Given this list of marker genes DPY19L1, USP28, SAP30, UTRN, MYBL1 (NCBI Gene Id 649850), MAP3K8, EOGT, TP53INP1, SLC27A3, TPM4, RHBDF2, KLRD1, PAM, MIAT, CYTOR, GAB3, ABCA2, CMC1, ELP3, RAP1GAP2, SESN2, SYTL3 (NCBI Gene Id 94120), TLR3, MIR155HG, TOB2, TTYH2, EOMES (eomesodermin), TOX, ANXA2, CAPN2, STARD3NL, PTP4A2, GYG1, ATXN1 (ataxin 1), SYT11, ADGRG1, RHOU, PTGDR, SH3BP5, MICAL2, CD58, KLRG1, LPCAT1, PDGFD, NKG7, CPEB2, ECPAS, JAZF1, WIPI1, GLCCI1, APMAP, GALM, SFXN3, HACD4, YWHAQ (tyrosine 3-monooxygenase/tryptophan 5-monooxygenase activation protein theta), BLVRA, ZEB2, SMAD3, PIF1, GALNT3, MDFIC, GZMA, TBK1, BHLHE40, MAN1A1, NUDT19, GFI1, PRR5L, LAG3, CLEC2B, SPATS2L (spermatogenesis associated serine rich 2 like), NIBAN1, TIGIT, TCIRG1, CAST, GFOD1, MRPL10, RUNX3, GCLM, PLCG2, STOM, YPEL1, ACTN4, VANGL1, LPP, PRF1, SERPINI1, CALHM2 (calcium homeostasis modulator family member 2), GPR137B, IL15, CASP1, PLEKHO2, SNTB2, DLG3, TBX21, SLC15A4, ACOT9, PLAAT3, GPR68, PTPRJ, SLAMF6, JAKMIP2, RGS3, SEMA4C, ARHGAP25, LINC02481, PIK3R3, ITGAL, AHNAK, TOGARAM2, SH2B3, S100A4, GBP5, CTSC, MAP3K5, ITCH, ATP2B4, SLCO3A1, ADAM8, MAGOH-DT, IFT25, RAB27A, KATNAL1, SLC2A1, SYNE2, C12orf75, MXRA7, TNFRSF1B, KAT2B, WSB2, AGO4, TSPOAP1, ARF6, PTPN22, ADGRG5, PYHIN1, AUTS2, GSR, SLAMF7, TTC38, ERN1, TGFBR3, COLGALT2 (NCBI Gene Id 23127), GZMH, HERPUD2, TMED9, IL10RA, EFHD2 (EF-hand domain family member D2), NEDD9, BCL2L1, B4GALT5 (NCBI Gene Id 9334), FGFBP2, PPP2R2B, MCTP2, GZMK, ARHGAP35, CHST11, MAF, SLC16A6, OPTN, RASGEF1A, SRGAP2, FAS, CST7, WWP2, FYCO1 (FYVE and coiled-coil domain autophagy adaptor 1), FCRL3, ZBTB38, OSBPL3, SMAD7, CNNM3, NDRG1, SH3BP2, TARP, FYN (NCBI Gene Id 2534), DOK2, HOPX, PLCXD2, MCOLN2, ZDHHC14, DNAJC1, JAKMIP1 (janus kinase and microtubule interacting protein 1), SANBR, PPP4R1, SP140, CD99, ADRB2, CCR5, APOBEC3G, KLF6, EPS15, DERL1, PHLDB2, SLFN11, RAB29, ANXA2P2, A2M-AS1, SRXN1, NPC1, CCL5, here is a description of the gene set: Human Gene Set: GSE26495_NAIVE_VS_PD1HIGH_CD8_TCELL_DN Genes down-regulated in comparison of naive CD8 T cells versus PD-1 high CD8 T cells. T cell dysfunction is an important feature of many chronic viral infections. In particular, it was shown that PD-1 regulates T cell dysfunction during chronic LCMV infection in mice and PD-1 high cells exhibit an intense exhausted gene signature. These findings were extended to human chronic infections such as HIV, HCV and HBV. However, it is not known if PD-1 high cells of healthy humans have the traits of exhausted cells. In this study, we provide a comprehensive description of phenotype, function and gene expression profiles of PD-1 high versus PD-1 low CD8 T cells in the peripheral blood of healthy human adults as following: 1) The percentage of naive and memory CD8 T cells varied widely in the peripheral blood cells of healthy humans and PD-1 was expressed by the memory CD8 T cells. 2) PD-1 high CD8 T cells in healthy humans did not significantly correlated with the PD-1 high exhausted gene signature of HIV specific human CD8 T cells or chronic LCMV specific CD8 T cells from mice. 3) PD-1 expression did not directly affect the ability of CD8 T cells to secrete cytokines in healthy adults. 4) PD-1 was expressed by the effector memory (TEM) compared to ‘terminally differentiated effector’ (TEMRA) CD8 T cells. 5) Finally, an interesting inverse relationship between CD45RA and PD-1 expression was observed. studied in species Homo sapiens from publication Duraiswamy J, Ibegbu CC, Masopust D, Miller JD, Araki K, Doho GH, Tata P, Gupta S, Zilliox MJ, Nakaya HI, Pulendran B, Haining WN, Freeman GJ, Ahmed R (PMID 21383243)